The following is a description of a gene set: Human Gene Set: HP_TYPE_1_MUSCLE_FIBER_PREDOMINANCE Type 1 muscle fiber predominance studied in species Homo sapiens An abnormal predominance of type I muscle fibers (in general, this feature can only be observed on muscle biopsy)., and this is the list of marker genes: GMPPB, LRP4, DPAGT1 (dolichyl-phosphate N-acetylglucosaminephosphotransferase 1), MB, TPM3, SLC25A12, PNPT1, SCN4A, CHRNA1, TPM2, MYH2, AK9, SELENON, TTN, TNNC2, CAV3, FKBP14, ALG14, MYH7, GDAP1, GYG1, RAPSN, RYR1, GFPT1, LMOD3, KLHL40, CHRND, FXR1, TAMM41, DOK7, KBTBD13, MAP3K20, KLHL41, SMN1, CHRNB1, MYF6, MYPN, VCP, LAMB2, SPEG, POMT1, STIM1, KCNA1, CFL2, ALG2, COL13A1, ACTN2, CHRNE, MUSK, HMGCR, UNC45B, NEB, GARS1, COL6A1, SGCG, BIN1, MTMR14, MYL1, ACTA1, AGTPBP1, RYR3, CCDC78, AGRN, DNM2, TNNT1, COLQ